The following is a description of a gene set: Genes up-regulated in peripheral blood mononuclear cell 3d vs 0d in adults (18-45) after exposure to Menomune A/C/Y/W-135, time point 3D Human Gene Set: LI_PBMC_MENOMUNE_A_C_Y_W_135_AGE_18_45YO_3DY_UP from publication Li S, Rouphael N, Duraisingham S, Romero-Steiner S, Presnell S, Davis C, Schmidt DS, Johnson SE, Milton A, Rajam G, Kasturi S, Carlone GM, Quinn C, Chaussabel D, Palucka AK, Mulligan MJ, Ahmed R, Stephens DS, Nakaya HI, Pulendran B (PMID 24336226) studied in species Homo sapiens Many vaccines induce protective immunity via antibodies. Systems biology approaches have been used to determine signatures that can be used to predict vaccine-induced immunity in humans, but whether there is a 'universal signature' that can be used to predict antibody responses to any vaccine is unknown. Here we did systems analyses of immune responses to the polysaccharide and conjugate vaccines against meningococcus in healthy adults, in the broader context of published studies of vaccines against yellow fever virus and influenza virus. To achieve this, we did a large-scale network integration of publicly available human blood transcriptomes and systems-scale databases in specific biological contexts and deduced a set of transcription modules in blood. Those modules revealed distinct transcriptional signatures of antibody responses to different classes of vaccines, which provided key insights into primary viral, protein recall and anti-polysaccharide responses. Our results elucidate the early transcriptional programs that orchestrate vaccine immunity in humans and demonstrate the power of integrative network modeling., and this is the list of marker genes: IMPG2 (NCBI Gene Id 51443), GPX1, LAMC2, TNF, A2M, CXCL8, SERPING1, CFH, PTX3, APOBR, CFB, MMP12, CARD9, IL1A (interleukin 1 alpha), IFNA7, C1QC, CCL20, IFNA2, IL1B, AMER2, C2, C1QB, C5AR1, IFNA16, C1QA, ST14, LHCGR, ARRB2, SFN